The following is a description of a gene set: from publication Cui A, Huang T, Li S, Ma A, Pérez JL, Sander C, Keskin DB, Wu CJ, Fraenkel E, Hacohen N (PMID 38057668) Cytokines mediate cell-cell communication in the immune system and represent important therapeutic targets. A myriad of studies have highlighted their central role in immune function, yet we lack a global view of the cellular responses of each immune cell type to each cytokine. To address this gap, the authors created the Immune Dictionary, a compendium of single-cell transcriptomic profiles of more than 17 immune cell types in response to each of 86 cytokines (>1,400 cytokine-cell type combinations) in mouse lymph nodes in vivo. A cytokine-centric view of the dictionary revealed that most cytokines induce highly cell-type-specific responses. For example, the inflammatory cytokine interleukin-1β induces distinct gene programmes in almost every cell type. A cell-type-centric view of the dictionary identified more than 66 cytokine-driven cellular polarization states across immune cell types, including previously uncharacterized states such as an interleukin-18-induced polyfunctional natural killer cell state. Genes negatively differentially expressed in cell type: CD4+ T cell upon treatment with cytokine: IL-1α in mouse lymph nodes in vivo. studied in species Mus musculus Mouse Gene Set: CUI_T_CELL_CD4_IL1A_RESPONSE_DN, and this is the list of marker genes: Adgre5, Selenop, Trbc2 (NCBI Gene Id 100125263), Septin1, Eno1, Tesc, Hspa1b, Cd37, Rassf2, Lbh, Cdc37, Tspan32, Arhgdib, Hvcn1, Cd3g, Ahnak, Arhgap9, Stk10, Ramp1, Smc6, Ms4a4b, Rgcc, Fkbp1a, Ppia, Myl6, Rasgrp1, Ift80, Bin1, Cd52, Prex1, Faah, Tuba4a, Itga6, Klf2, Commd8, Itgb1, Tnik, Add3, Arrb2, Chd3, Bin2, Bcl11b, Tbc1d10c, Lcp2, Evl, Pycard, Spn, Lrrfip1, Itpkb, Trbc1, Rac2, Stap1, Ugcg, Anp32a, Flna, Nsg2, Kif21b, Cd84, Tmsb10, 9930111J21Rik2, Gpr174, Emp3, Thy1, Foxp1, Septin9 (septin 9), Adcy7, Calm1, Cd28, Macf1, Cd6, Cd4, Cd40lg, Znrf2, Capg, St8sia6, Esyt2, Coro1a, Ncor1, Ptprcap, Grap2, Srpk2, Saraf, Limd2, Lgals1, Mgst2, Pdlim4, Tagln2, Ccdc88c, Stk38, Fyb1, Smpdl3a, Pdk1, Themis, Sh3bgrl3, Apbb1ip, Smc4, Trat1, Mxd4, Cd2, Rgs10, Fam78a, Cd48, Clec2d, Lcp1, Rhoh, Ms4a6b, Myh9, Ikbkb, Tent5a, Lsp1, Cd5, Rbm38, Crip1, Itgb7, Actn1, Grap, Orai2, Ripor2 (RHO family interacting cell polarization regulator 2), Btg2, Pitpnc1, Shisa5, Zmiz1, Hspa1a, S100a10, Actr3, Fxyd5, Tecpr1, Ass1, Dapl1, Cd27, Hsd11b1 (NCBI Gene Id 215261), Cd44, C1qbp, Klf6, Rasgrp2, Ltb, Jun, Septin6, Mif, Id3, Arhgef1, Ankrd44, Cdc42se2, Itga4, Cotl1